Given this list of marker genes FUCA1, GLA, FUCA2, GBA1, GBA3, GBA2, NAGA, here is a description of the gene set: Human Gene Set: GOBP_GLYCOSIDE_CATABOLIC_PROCESS species: Homo sapiens The chemical reactions and pathways resulting in the breakdown of glycosides, compounds in which a glycosyl group is substituted into a hydroxyl, thiol or selenol group in another compound.